The following is a description of a gene set: Human Gene Set: E2F5_TARGET_GENES from publication Yevshin I, Sharipov R, Kolmykov S, Kondrakhin Y, Kolpakov F (PMID 30445619) Genes containing one or more binding sites for (E2F5) in their promoter regions (TSS -1000,+100 bp) as identified by GTRD version 20.06 ChIP-seq harmonization. studied in species Homo sapiens, and this is the list of marker genes: UBE2E2, DOLPP1, HMG20A, SUMO2, TIAL1, FBXO31, RAB7A, RBM6, CCDC144CP, MAD2L1BP, ZNF687, KBTBD6-DT, CFAP95-DT, ARMH4, CMIP, ACTL6B, MAX, MEF2C-AS1, RDH10-AS1, RAD51-AS1, ALDOA, RHNO1, NMRK1, ENSG00000223528, RTEL1, NFASC, ZBTB12, EDC3 (NCBI Gene Id 80153), ENSG00000235978, KRR1, CSTF3, CADM3-AS1, RPS13, CCNA2, FOXM1, ANKS6, APLF, RHOA, NR3C1, DEDD, CTCF-DT, SPC25, MIR3124, EIF4H, IPO13, FAM200B, TEDC2, LINC02918, HTRA2, ASAP3, VTRNA1-3, ARID4A, CARD8, RACGAP1, THYN1, WRAP53, TUBGCP3, H2AC16, PHF13, AAMP, ZNF280C, AIRIM, LONRF1, MCM5, CTDP1 (CTD phosphatase subunit 1), SBK1, PDS5A (NCBI Gene Id 23244), NUP54, BORA, ATP6AP1L, AIDA, DYNC1I2, ST20, FUZ (fuzzy planar cell polarity protein), RPIA (ribose 5-phosphate isomerase A), RIN3, SYNCRIP, SASS6, NSMCE1-DT, ZNF605, KIAA1143, SRSF1, NUCB1, ATE1, TMEM11, STMN3, PCED1B-AS1, FBXO46, UBR3, CCAR2, RNVU1-27, TRAPPC3, HINT3, ZNF56P, PDIK1L, QRICH1 (glutamine rich 1), HERC1, ZSCAN31 (zinc finger and SCAN domain containing 31), AGO4, SZRD1, ARPC2, SLC7A7, KIF18B-DT, SNX5, ENSG00000232732 (novel transcript), NOP53, ZNF133, LINC02268, PRMT3, RNF130, SDK1, LHFPL4, HEPH, CCDC146, HM13, UTP11, ENSG00000266401, TBC1D8B, PABIR3, USP48, GTF2H2C, RAD54L, TP53, GP6, KDM7A-DT, AKIRIN2 (NCBI Gene Id 55122), EXOC6, ALG6, HIF1A, SLC6A6, CLTC (NCBI Gene Id 9511), MTMR4, SCRT1, ADO, ENSG00000246465, RYK, TPGS1, GATA1, C18orf54, NTHL1, ARPP19, LINC02928, CXXC1, HMGB1, CKAP5, MAPT (NCBI Gene Id 8152), LINC02983, SEC24C, CTTN, MAD1L1 (NCBI Gene Id 8379), ATG4B, NELFCD, SCAF1, CFAP161, C19orf38, TM9SF4, NNMT, ZNF175 (zinc finger protein 175), TCTA, TMBIM1, TPRKB, ZNF436-AS1, TCIRG1, SPINK4, CEP89, LINC02543, DCK, LEPROTL1, QTRT2, GRAMD4, RNU5D-1, MLLT6, RPGRIP1L, PCSK1, CCDC191, RAD51, FAM178B, YME1L1, ADORA3, CHCHD2P1, NUF2, RANBP10, EFNA3, TOR2A, LINC01424, HTR5A, SYT3, BOD1, TK2, SEPTIN7P9, ZNF155, RBKS, KCNS2, C4orf46P2, KCNK1, CMSS1, MIR4729, CHFR-DT, MIF4GD, MTFR2, VPS35, ENSG00000227245, B4GALT3, IFI27, NOP14, VPS35L, RBBP4, SNHG20 (NCBI Gene Id 654434), NEIL3, MYO6, CCDC115, ZNF10, SPTAN1, F2RL3, SNORD48, TAL1, MAK16, BSG, BIRC5, LINC02610, OR51A6P, RPH3AL, DEPDC1B, H2BC11, ATXN7L3, MITF, RRP1B, UBE2E2-DT, MZT1, MCM6, C19orf53, APAF1, ZNF589, MED25, CARMIL2, SLC4A2, FOXA3, CA1, LAMTOR2, CUTC, CDK12 (NCBI Gene Id 51755), CDCA8, SAXO5, FASN, SLC25A11, XYLT2, SUMO3, TTBK1, ACAD9, MAP1LC3B, PRR5, HNRNPD-DT, AFDN, PTP4A3, NOS3, PANK4, STAP2, LRFN4, HNRNPD, TULP2, GRK3-AS1, LINC03023, NFE2, FBXO48, NPRL2, KCNH6, MINDY2-DT, THAP4, TSSK3, FNBP1, TRIM29, ANKRD11, LINC02068, ZNF420, KMT2B (NCBI Gene Id 9757), HMGN2P34, CFAP95, ZFYVE1, TTLL4, GRK3, PARPBP, VCPIP1, AP2A2, ERP44, LGALSL-DT, TRAK2, REXO2 (NCBI Gene Id 51640), ANKRD34C-AS1, COX7B, USP28, MCM7, TIMM21, XPO6, FBXL20, ZAR1L, VAC14, SARDH, PXN, FBXL5, VHL, PGP, RN7SL824P, PDE3B, HDAC5, NDC80, ZNF41, RUNX1T1, FN3K, CENPT, MPI, H2BC13, ANKZF1, GSPT1, PNPLA6, VIPAS39, PACS2, ZFYVE19 (NCBI Gene Id 84936), ESPL1, E2F2, BLM, NEDD4, TMEM131 (NCBI Gene Id 55369), ZBTB46, MOB4, EMC3-AS1, CHAMP1, PLEKHF2, PPP5D1P, GLRA1, RPS27, DAZAP1, ZHX1-C8orf76, LIFR, SMARCA4, TULP3, TSPAN7, ZBTB11, UBE2Q2, AGPS, FBXO38 (F-box protein 38), RABGAP1L, DUT, GAREM2, LMNB2, RABGAP1L-DT, TRPC7, UBTF, TPH2, ATG9A, CFLAR-AS1, CCZ1P1, DMXL2, LASP1 (LIM and SH3 protein 1), LARP7, PEX26, TPX2, CCDC124, GRHL1, MCM2, PI16, RAD51B, LMNB1, PKN1, SPG11, NTAN1, STK25, PTPRN2, RGS5, MKKS, TMEM14B, IKBKB-DT, MDM2, ANXA5, RCCD1-AS1, ACTR1A, FASTKD1, FBXO15, UBR2, KCNAB1, PAFAH2, SEZ6, RNF213, HMGN2, VRK3, LINC01898, RHOBTB3 (NCBI Gene Id 22836), ZNF280D, ZNF573, CLDND1, SNAP25-AS1, VOPP1, GFUS, HASPIN (NCBI Gene Id 83903), FBRSL1, CDCA5, ENSG00000232995, BIN1, C2orf69 (chromosome 2 open reading frame 69), LYN, ACSF3, ZBED6, AHI1, STN1, IQGAP3, SHLD2, MKI67 (NCBI Gene Id 4288), RUFY1, ZNF444, RABEP1, SELPLG, CHFR, SKA1, CIDECP1, CCZ1B, LIN9, CARD8-AS1, FAM185BP, C11orf21, FAM83A, ZNF785, SCG3, CACNA1A, PNKD, TP53BP2, NRDE2, RPL17P41, CCP110, ZNF585A, PPID, STAT5B, TTC33, KIF20B, TK1, INTS1, LEMD2, ADD1, BRD3, MRPL27, KIAA1586, NEUROD4, DIAPH3, SNHG32, UBE2E3, ZYG11A, WDR13, HSF2BP, SNX1, IFT140, NOP58, HECTD2, NPEPPS, PPP1R15A, PIK3AP1, LARP4B, CHIC2, TIMM22, ABCA5, ZW10, SCMH1, ZNF235, MIR5093, HEMGN, ASPH, FBXW11, POLE2, SH3GL1, IKZF2, YPEL4, CCDC163, SLK, NUDT13, PDE6D, NIFKP7, UBE2V1P4, ZNF821, AHSA1, ZFX-AS1, MPND, NPPB, CDCA2, LINC01056, EPC1-AS1, NUDCD1, ZFX, PTBP3, STAT1, COX7C, NR1H3, WNK1, ARMH3, SCG2, USP20 (ubiquitin specific peptidase 20), GRK4, WBP2, CHPT1, RRM2, FARSA, ENSG00000189229, SYMPK, LIFR-AS1, TMED5, KAT7, STC2, VILL, AURKB, ACTG1, UBE2Q1, SHCBP1, VKORC1, NUCB1-AS1, ODAD3, MBTPS2, PHF12, FCHSD2, MIR7-3, SHLD1, H2AX, CSGALNACT2, MEF2C, VMP1, TBX6, ANKMY1, CLPX, USP39, RPS23, GEN1, NFE2L2, ANO7, KCNC3, RPL23A, LINC01929, AP2S1 (NCBI Gene Id 9161), ORC6, RXRA, RBSN, CCHCR1, C1orf159, CPXM1, ZNF331, TLCD3B, GBA1LP, IZUMO1 (izumo sperm-oocyte fusion 1), TCEANC2, HAUS8, CTTNBP2, ZCCHC7, EIF3F, GNB1, UNG, HIKESHI, SPCS3, SNX12, UBAC1, CSNK1E, LINC01433, HSPE1-MOB4, BUB3, C19orf81, CSNK2B, REN (NCBI Gene Id 5972), UNC13A, OSTF1, ZBTB8OS, LINC00996, NSD2, DIAPH1-AS1, CA12, PRCP, LNCATV, CAMKK2, SYNGR1, CRADD, SCGN, ZNF32, DUSP14, CCDC137P1, RALBP1, KPNA3, PHB1, EOGT (EGF domain specific O-linked N-acetylglucosamine transferase), C16orf95, KIF18B, MAGOHB, ZNF337, ZNF225, TSNAXIP1, FBXO5, GNB4, ALG10, ZNF451, ALB, TBC1D31, MYO9B, HOOK3, NFXL1, CHCHD2, PTBP1, SNRPD3, PTMS, GCSAML, POLE, SLC44A1, CDC40, PHF21A, PPM1A, FBXO38-DT, IFT80, BRD9, PCSK6-AS1, GINS2, FBXL16, BTBD3, SLC48A1, RN7SKP192, AFDN-DT, BANP (BTG3 associated nuclear protein), IFRD2, GBA1, ENSG00000228395, TPRA1, ATP5MF-PTCD1, CLEC16A, ZFYVE28, MDH1, HTR1A, FAM237A (family with sequence similarity 237 member A), UBE2T, DOT1L, MAT2A, MRPL52, NSD1, RPP40, UBL4A, PCSK6 (proprotein convertase subtilisin/kexin type 6), NAB2, CPLX2 (complexin 2), AHCYL2, ZNF436, IMPACT, TMTC3, ADNP, ENSG00000254718 (novel transcript, antisense to  PPM1A), CDKN3, GTF2IRD1, PLXNA3, BARHL1, RANBP1 (RAN binding protein 1), KAT14, AHCTF1, RPF1, RCCD1, MUS81, FAM111A, STAU1, NCOA5, RN7SKP245, PEAK1 (NCBI Gene Id 79834), TMEM115, ZFPL1, ZNF473, CPLX3, SIGLECL1, GPAT4, BICDL1, RFC3, HNRNPA1P52, RBL1, SLC17A6, TMIGD3, LINC01287, PLK1, MARCHF4, PIAS1, ELOC, LINC00663, P4HTM, MACC1, TGFBR3, TSC2, ENY2, CPNE2, VOPP1-DT, TTC13, RAB29, TRMT2A (NCBI Gene Id 27037), CPED1, RPL36AP7, E2F1, TRMT13, UBXN2B, ZFP37, NMT1, ADSS2, BDH2, PXMP2, FAM117A, GNG4, ZNF37A, ADAM9, ZNF615, ZNF350, TLE5, CHEK2, SCRIB, STMN1, CCDC136 (coiled-coil domain containing 136), E2F3, STRIP1, AP2M1, GPR6, CSGALNACT2-DT, TMEM179, ENSG00000187951, LINC00964, NINJ2, ENSG00000225649, ACBD5, RCN3, CEP290, CELF6, KLF13, ADCY9, RNU6-169P, CTBP1-DT, MALAT1, SMC6, CDK5RAP2, STAT3, RNA5SP60, SLC8B1, ANP32E, KIF22, TMED1, DLGAP5, CDCA7, MINDY2, CLP1, OAZ1, TNRC6B-DT, CTCF, DPYSL2, RAB30-DT, GP6-AS1, PLAAT5, WWC2-AS1, LARS1, CENPO, GVQW3, DCAKD, TBC1D4, PPM1E, TFAP2A, CALR3, GYPB, RPS20, MIS18BP1, RNA5SP404, PATZ1, KBTBD2 (kelch repeat and BTB domain containing 2), APBB1, EME1, SVOP, RPL13A, PKD1L2, LYSMD1, ZNF354A, EEF2K, DDIAS, SGPL1, TMEM201, ATP7A, CHD4 (chromodomain helicase DNA binding protein 4), DGCR8 (DGCR8 microprocessor complex subunit), ZNF45, FANCD2, FEM1A, INHA, MAN2A2, GAB2 (GRB2 associated binding protein 2), SLX4IP, HSPE1, SEC61A1, TKT (transketolase), CENPS, MIR4515, ENSG00000255491, FGFR1, PRKD1, HMBS, XRCC3, ATE1OSP, METTL3, MYCL, SMARCAL1, PTMA, UBE2G2, ANKRD12, C1orf174, BSN-DT, PCED1B, EXOSC2 (exosome component 2), LSM10, CHEK1, NEMP1, ZNF341-AS1, RNF170, FAM53C, EML6, ADGRB3, PDE4C, ACAD8, INVS, MAU2, CCDC88B, PDS5B (NCBI Gene Id 80197), ATP5MF, CENPF, IRAIN, KIAA0232, PLSCR2 (phospholipid scramblase 2), NDUFV2-AS1, KDM7A, PXT1, CEP128, NYAP2, NOXO1, NKAIN1, ARHGAP11B-DT, ZHX1, LPIN2, AUP1 (AUP1 lipid droplet regulating VLDL assembly factor), SIAH1, POGLUT1, RNF227, METTL2A, WDPCP, CIAO2A, PPP2R3B, SNHG5, CP, MARS1, TFEB, COMMD3-BMI1, SIK3, RAB39A, ENSG00000230773, NUTF2, DTNB, MIER1, MADCAM1, BTBD1, CASP8AP2, FBF1, SAP30-DT, PSMA1, MASTL, AMMECR1, DEPDC1, SRRM3, CCDC88A, MIR130AHG, H2AC11, IKBIP (IKBKB interacting protein), SNAPC3, SRCIN1, NCKAP1L, CTBP1, MFAP1, SLC35F2, TNFRSF19, NBPF12, ATP13A1, STARD7, SGO1, CYB561D2, PTRHD1, PPP1R12C, OGDHL, UPF1, GPR158, GYPE, RERE, CSTF3-DT, SYN1, VPS50, SNORD54, CDYL (chromodomain Y like), FNBP1P1, AFMID, SOX12, DUS1L, LMNB1-DT, MIR4706, KCTD9, GATB, KCNB1, AP4M1, CALM3, SLC14A1, SMC4, CFAP99, TOR1A, WWP1, SMPD3, IKZF3 (IKAROS family zinc finger 3), GPANK1, VTI1B (NCBI Gene Id 10490), TCF4, OPLAH, CENPW, GFER, MRPS25, FAM168B, UCK1, THAP1, FEZ1, HNRNPF, ATF7IP2, CCDC159, CALCOCO1, CHCHD6, ZNF484, XKR4-AS1, FANCC, DDX23, GPR19, ALDH5A1, PIGL, S100Z, TTC9B, CCDC18, CACTIN, CANT1, BABAM1, LINC00029, BABAM2, VTN, METTL4, WASF1, FGF7, NPRL3, SULT4A1, GDAP1, MYO18B, SERBP1, ARHGEF2, SAP30, GALM, SLC39A3, CCNB2, ZNF239, ATAD5, ZNF649, C10orf95-AS1, GPT2, RNU6-218P, SAV1, ENSG00000253986, RMDN3, SSH1, TMEM181, SYT14, ARV1, SETMAR, HDAC6, TMEM59, ST18, PSMB5, TACC1, UBE3C (ubiquitin protein ligase E3C), MIR4736, ALG1L13P (ALG1 like 13, pseudogene), CLSTN1, TNRC6B, CYB5R4, DNAJB2, ZC3H11A, RTKN2, SEL1L, FAAP24, ARHGAP5, CLINT1 (NCBI Gene Id 9685), LIN54, FRMD1, LINC03108, SUGP1, MED15, GIRGL, TM2D2, MIDEAS, NRSN2-AS1, MIR7-3HG, ING3, RNF167, RPL7AP83 (ribosomal protein L7a pseudogene 83), USP3, CDCA3, PTCD1, SSBP4, SORBS1, COX15, EPC1, SELENOKP2, COPS7B, ALKBH8, MRGBP, MIR4470, CENPS-CORT, SPIRE2, WT1-AS, DUSP28 (dual specificity phosphatase 28, NCBI Gene Id 285193), NF2 (NCBI Gene Id 654093), PSMA3-AS1, PBK, CENPA, H2BC16P, SLC45A4, GUCD1, HNRNPU, NOLC1, UBE2O (NCBI Gene Id 63893), VAPA, MTF2, HSPA9, RALGDS, PODXL2, MCM4, ZNF268, BCAS2 (BCAS2 pre-mRNA processing factor), BRCA2, LHFPL5, FPR1, HSPD1 (heat shock protein family D (Hsp60) member 1), STXBP5-AS1 (NCBI Gene Id 731843), SYCE2, DNAJC17, SNIP1, MMACHC, KAT6A, BROX, KIF15, UBXN2A, UBE2E3-DT, IFRD1, GRM1 (glutamate metabotropic receptor 1), COL4A2, HPN, PIPOX, TOP2A, ZFYVE21, TBL1X, ZBTB14, PAN2, CHD7, STING1, C11orf58, ARHGEF39, TMEM11-DT, FYCO1, H4C8, HCG20, FAM222A, PRKCSH, DESI1, ABRAXAS2, TMEM160, CRAMP1, HROB, QTRT1, GRM7, TCAM1P, GNB1-DT, XRRA1 (X-ray radiation resistance associated 1), CECR2, MARCHF2, RIC8B, STARD6, RTEL1-TNFRSF6B, PTDSS2, YEATS2, LRP4-AS1, IL18RAP, IGF1R, MELK, RNU4-2, ORMDL3, ENSG00000213963, SLC12A8, BRD4, CNPY2, XIST, STIL, MCM3, FAM193A, NELFA, ATAD2, CFL1, TMEM33, PRKCE, DLGAP4, CWC22, RN7SKP91, LUC7L, OSBP2, NCAPH, B4GALT2, CDH23, OTUD7A, SCAMP5, INHBE, BUB1B, ENSG00000237346, LUC7L2, FHL2, CDK5, PPCDC, CENPV, UBQLN4, PCBP1-AS1, MGME1, TOMM40L, LGALSL, BTNL9, PHLPP1, LINC02252, CCDC174, TMEM70, KBTBD7, GPBP1L1, C19orf44, NOSIP, FANCI, LINC01521, PET117, IL1R1, STRADB, HMGB2 (NCBI Gene Id 3148), ITGAE, COMMD3 (NCBI Gene Id 23412), ZNF614, SMIM30, RRM1, DIAPH1, CRTC2, RFC4, ST3GAL2, EHD1, OBSL1, TPBGL-AS1, MADCAM1-AS1, CDC25C, MIR4710, TXN2, TCF19, NEK6 (NCBI Gene Id 58167), DVL2, LINC01560, SNORD42B, TFDP1, SRD5A3-AS1, ACRBP, CCDC71, UBA5, RNU2-17P, LRRC61, METTL15, CHRNB1, AFG2B, PTAR1, USF2, AKR1E2, RAB30, CHMP4B, SMUG1, MAPK8IP2, FZD3, ERVK3-1, SCNM1, DENND1A, NUP37, ZNF84, ADGRB3-DT, VRK1, IRF2BP2, ADGRG3, HSCB, TRIP13, CERNA3, AKT2, TXNDC15, SOX6, TCP11L2, CRTC3-AS1, TMEM150A, VDAC2, CDK11A, TMEM69, CBFA2T3, AMIGO1 (NCBI Gene Id 57463), CABIN1, USP31, ZNF217, ACTN4, LINC02777, CALB1, PRR14, CEP295, CCNG2, ZNF84-DT, THUMPD2, LINC03099, DNAL1, YJU2, GLUD1 (NCBI Gene Id 2746), PRKDC, FAM110A, ENSG00000266976, RNU1-108P, TMEM145, SLC35A1, NPEPPSP1, LINC01732, RN7SKP168, KBTBD6, H2AC13 (NCBI Gene Id 8329), EMC3, CTNNA2, NAGLU, SEC14L1, TCP11L1, ATP2A3, ZNF367, SNX16, UBE2L3, RNF10, MANEAL, MFAP3L, ACP2, BTRC, NADK2, MOSPD2, USP6NL, BMAL1, KCNK12, GTPBP2, MYO3B-AS1, THAP12, PPP4R1L, ARHGAP25, ENSG00000232884, ARHGDIA, IMP4, MIR4766, ZGRF1, KCTD20, TRIR, NUMA1, ST7, EPC2, NUDT2, IL23A, FBLL1, ARRDC3, MYB, SAMD9L, ARHGAP5-AS1, MIF4GD-DT, PRKCA, BANCR, ACOX2, PCK1, FANCB, ACSM4, TMEM39A, TCEA2, FTO (FTO alpha-ketoglutarate dependent dioxygenase), DUT-AS1, SGO1-AS1, SPTBN4, RANGAP1, ZNF185, HCLS1, ACSL6, TMPO-AS1, HMX3, RNA5SP324, ZWINT, STON2, ACVR1B, SPCS2, HMGB3 (NCBI Gene Id 3149), MEGF11, SLC38A1, SH3BP5L, UCKL1, ENSG00000224905, KNSTRN, ZNF225-AS1